The following is a description of a gene set: Human Gene Set: MIR6886_5P from publication Chen Y, Wang X (PMID 31504780) Genes predicted to be targets of miRBase v22 microRNA hsa-miR-6886-5p in miRDB v6.0 with MirTarget v4 prediction scores > 80 (high confidence targets). studied in species Homo sapiens, and this is the list of marker genes: NKX2-5, KLK4, PPP4R1, TP63, TBC1D5, CFAP20, WNK1, DGKQ